The following is a description of a gene set: species: Homo sapiens Human Gene Set: GOMF_COMPLEMENT_RECEPTOR_ACTIVITY Combining with any component or product of the complement cascade and transmitting the signal from one side of the membrane to the other to initiate a change in cell activity., and this is the list of marker genes: FPR2, C3AR1, GPR32, GPR32P1, CR2, FPR1, FPR3, C5AR1, C5AR2, GPR33, CR1, CMKLR1